The following is a description of a gene set: species: Homo sapiens Complement cascade Human Gene Set: REACTOME_COMPLEMENT_CASCADE, and this is the list of marker genes: FCN2, COLEC11, IGKV1-5, GZMM, ELANE, C2, IGHV3-53, CFI, IGHG4, IGKV1-12, CRP, C7, IGHV3-30, IGKV3-15, IGLV2-14, IGKV1-39, CFHR3 (NCBI Gene Id 10878), IGHV3-7, IGLV3-19, CD19, IGHV3-23, CFHR2 (NCBI Gene Id 82725), C4BPB, CD55, C1QC, IGKV2D-40, CFHR4, C4B_2, IGKV2D-30, CFH, PROS1, IGHV3-33 (immunoglobulin heavy variable 3-33), VTN, C1R, C5AR1, IGKV3-20, IGKV1D-16, IGHG2, FCN3, IGKV4-1, IGKV1D-39 (NCBI Gene Id 28893), IGHV3-11, C8G, CR2, IGHV2-70, IGLV1-44, IGHV4-39, IGLV2-8, IGKV1D-33, IGKV3D-20, FCN1, C4B, IGHG1, C3, IGHV3-13, CD59, IGHV4-59, C1S, IGKV1D-12, CLU, IGKV2-28, CFHR5, CD46, C9, IGHV1-69, C8B, CFP, IGHV1-46, IGHV1-2, CPN2, CFHR1, IGLV2-11, IGLV1-40, IGKV1-33 (immunoglobulin kappa variable 1-33), F2, C4BPA, C4A, IGLV7-43, C5, IGKV1-16 (immunoglobulin kappa variable 1-16), MBL2, CR1, IGKV2D-28, C1QA, IGLV6-57, C6, CFD, C8A (NCBI Gene Id 731), C1QB, CPN1, C3AR1, IGLC2, CPB2, IGLV1-47, IGHV4-34, IGKV1-17, IGLC3, IGKV3-11, IGKV5-2, IGLV3-25, CFB, IGKV2-30, C5AR2, IGLV3-21, IGLV3-1, IGLV3-27, MASP1, IGHV3-48, CD81, IGLV1-51, COLEC10, SERPING1, IGLV2-23, IGHV2-5, MASP2 (NCBI Gene Id 10747)